The following is a description of a gene set: species: Homo sapiens The controlled release of proteins from a cell at the sides which interface adjacent cells and near the base. Human Gene Set: GOBP_BASOLATERAL_PROTEIN_SECRETION, and this is the list of marker genes: AP1S1, AP1B1, AP1M2 (adaptor related protein complex 1 subunit mu 2), SLC4A8, AP1G1